Given this list of marker genes SAMD9, CDH23, MAX (NCBI Gene Id 4149), PTEN, KCNQ1OT1, CACNA1S, VHL, TERT, ZNRF3 (NCBI Gene Id 84133), CDKN2C, NR3C1, PRKAR1A, DLST, KRIT1, CYP11A1, YY1, TNXB, NKX2-6, BCAP31, NUAK2, HYLS1, PROKR2, PLXND1 (plexin D1), CTNNB1 (catenin beta 1), SDHD, PDCD10, ZMPSTE24, BMP4, LTBP4, CCND1, CYP11B1, CILK1, ARMC5, PDE11A, ATRX, BRAF, WNT3, DPYSL5, LMNA (NCBI Gene Id 7816), TMEM127 (NCBI Gene Id 84178), NSDHL, MKS1, ATP6V1B2, CDKN1A, PEX1, POMC, CLCN2 (chloride voltage-gated channel 2), LIPA, SLC25A11, CDKN1B, POR, IGF2 (NCBI Gene Id 492304), PRKACA, SIX3, CCM2, KCNE3, PIK3CA, STAR, ADH5, MEN1, SDHA, LHX4, VPS35L, CDKN2A, SDHC, GLI3, APC, MDH2, HESX1 (HESX homeobox 1), SCN4A, WDR11, CHEK2, GK, GPR161, ABCC6, TBC1D7, ENPP1, POLE, IDH2, FH, NR0B1, CYP17A1, CDKN2B, GNAS, CYP21A2, KIF1B, CYP11B2, SDHAF2, RET, ROBO1, CCDC22, AIRE, PDE8B, TBC1D24, TBX19, CDON, ABCD1, SDHB, EPAS1, CACNA1D, KCNQ1, CDKN1C, KCNJ5, ADA, KDM1A, USP8, HSD3B2, TBX1, MTHFR, VANGL2, MDM2, WASHC5, WNT4, NF1, IDH1, USP48, TP53, DNMT3A, here is a description of the gene set: Abnormal endocrine morphology Any anomaly of the structure of an organ ofthe endocrine system. studied in species Homo sapiens Human Gene Set: HP_ABNORMAL_ENDOCRINE_MORPHOLOGY